Given this list of marker genes ATXN1, KIAA1328, CNTD1, SLC8A1, DOCK3, CASP14, PHF21A, SRGAP2, RALGAPB, ZNF586, EFTUD2, CACNG4, YWHAG, LCOR, RORA, SF1, KLHL29, SIX3, FZD4, ZNF662, EYA3, UBE2H, XYLB (xylulokinase), ACACB, PCDHA9, CEP15, PCDHAC1, TAF5L, FAM135B, GEMIN8, ZNF557, RCC1L, LINC03043 (NCBI Gene Id 402589), CXCL9, TOX3, TRIM66, ADH4, PCDHA7, MECP2, WDCP, ARF3, MTCL2, SMCO4, TAP2, ANKFY1, SIX1 (NCBI Gene Id 6495), CA10, SCD, TSPAN18, TTBK1, PMF1, LRIT1, CENPO, CDYL2, ZCCHC12, GEMIN7, GPNMB, KLF7, FCRL3, FOXN4, TUBGCP3, BCAT1, FBXO41, BSN, SNAP25, FAM163B, PCDHA13, EIF2AK1, FAM234B, B3GAT1, CSMD2, PAK6, RASEF, SYN1, ISG20, POPDC2, PARP11, DLG2, PCDHAC2, PM20D1, SSTR2, ARMC8, GNB3 (NCBI Gene Id 2784), KANK2, PRR5L, HIF1AN, TPMT, RAE1, NCAPH, SARNP, CCND2, AKAP6, RNASEH2B, KPRP, CARD18, GRIN2B, COMMD2, SLC25A28 (solute carrier family 25 member 28), PRR23A, KCNK9, KCNN3, CNTLN, FBXL17, EFCAB2, EPHB2, PCP4, MS4A2, GRB2, KCNJ5, GPX3, USP3, TTC28, CEP104, TBC1D19, SLC16A2, TERB2, RAB35, FIGNL2, PLEKHA5, ATAT1, EPB41L1, ADRA1A, JAGN1 (NCBI Gene Id 84522), MAPK13, ZNF473, SLC30A3, SMG7, LYN, ZNF444, FAM222B, TCF12, SPTB, KLK5, GTF3C4, DNM1, GINS1, TBC1D5 (NCBI Gene Id 9779), PXT1, CNTNAP5, HCCS, BTLA, EXOC6B, SDF2, ZNF236, CDC42, SSX1, GJA5, FOXP4, HCN4, LAMP5, INTS6, GPR84, FMN1, ELOVL4, PCDHA4, TRIM58, CPNE6, TCP1, USB1, NFATC3, SHISAL1, CGN, ETV3L, GSTA4, ZNF2, PCDHA10, NBN, PCDH10, MSI1, PCDHA5, TMEM150C, PREPL, SIPA1L1, UBE2D4, PIM1, PCDHA1, PCDH9, PGLYRP4, SBK1, ATP6V1F, RIC8B, CD300LD-AS1, ENC1, RERE, MRPL34, TBC1D30, TPD52L1, CARF, ORC5, WNT9B, FANCD2OS, RHOT1, HOOK3, PCDHA11, ARID1A, SORL1, EPPK1, DCX, PBX2, MTHFS, SNX30, AR, MAB21L2, CFAP44, NETO1, NPNT, METTL25B, SEL1L3, BASP1, NR1D1, RNF20, UBXN10, HDX, CCNL2, RDX, KAT6A, MLLT11, ERCC6, NMNAT2, MAT2A, PCDHA8, MON1B, CDH4, SOX5, CTDNEP1, SPATA2, CHMP7, ADAM22, PATZ1, MAU2, PCDHA3, HP1BP3, ST20-MTHFS, RIMOC1, CD209, ADGRB1, PCDHA12, HDAC5, STX6, ITPRIP, MS4A3, ABCG4, ABCG1, ADGRL1, SIX2, GJA1, NCAN, SOX13, FANCA, LRRC32, XKR5, CNOT9, ULK4, AKR1C2, DCTN3 (dynactin subunit 3), ZNF704, PPP1R3B, XYLT1, ATP1A3, FAM76A, GATAD1, PLEKHB1, TMEM165, LDLR, SH3BP2, MXRA5, FAM151B, PALM2AKAP2, SGMS1, DTNA, DDX18 (DEAD-box helicase 18), SPATS2 (spermatogenesis associated serine rich 2), SLC17A2, USPL1, TMEM139, CSRNP2, SYNM, HOPX, HIC2, WNT1, EMC10, HIPK2, SIGLEC1, NOTCH2, SUMF2, DEFA5, TRPM3, DYNLL2, PRKAR2A, MIER1, YIPF1 (NCBI Gene Id 54489), ANKRD45, LHX2, MRPS21, RHOA (ras homolog family member A), PHLDB1, NHLRC2, SNTB2, RGS8, PCDHA2, SREBF2, PCDHA6, here is a description of the gene set: studied in species Homo sapiens from publication Chen Y, Wang X (PMID 31504780) Human Gene Set: MIR4644 Genes predicted to be targets of miRBase v22 microRNA hsa-miR-4644 in miRDB v6.0 with MirTarget v4 prediction scores > 80 (high confidence targets).